Given this list of marker genes Pias1, Atp2b4, Prkci, Cacng2, Rer1, Cnpy4, Rhog, Agr2, Acsl3, Rab38, Cib1, Pdpk1, Sqstm1, Lrp1, Myo5b, Gnai1, Grip1, Efcab7, Snca, Ephb2, Pkp1, Akap5, Stac, Rab11a, Vil1, Actr3, Pgrmc1, Rangrf, Zdhhc5, Ramp3, Kcnj11, Arhgef16 (NCBI Gene Id 638799), Rack1, Itgb1, Epha3, Clip3, Ptpn9, Atp2c1, Egfr, Numa1, Pls1, Akt1, Gpsm2, Prnp, Eif4g1, Dlg1, Wnt3a, Stx4a, Dpp6, Vps35, Ppp1r9b, Wnk3, Stac2, Cln3, Lgals3, Kif5b, Epb41l2, Gper1, Ezr, Arf6, Tnf, Epha2, Sorbs1, Nkd2, Sptbn1, Rab11fip2, Epb41, Dpp10, Cnst, Stac3, Zdhhc2, Trem2, Nrxn1, Commd1, Myo5a, Itga3, Stx3, here is a description of the gene set: species: Mus musculus Mouse Gene Set: GOBP_POSITIVE_REGULATION_OF_PROTEIN_LOCALIZATION_TO_CELL_PERIPHERY Any process that activates or increases the frequency, rate or extent of protein localization to cell periphery.